Given this list of marker genes AP3B1, OPTN, CTDSPL, MYL9, PARD3 (par-3 family cell polarity regulator), CALM2, HIRA, MGAT5, TRIM22, NECTIN2, ZBTB20, RBMS1, PLOD2, KLK7, ARMCX2, SNX19, DST, PSMA3, ERBB4, CANX, BEX4, ADD3, ATP13A3, RBBP4, SPOCK1, SACM1L, GDE1, FAT1, UBE2L6, POSTN, KLK6, HNRNPC, DUSP14, RAI14, DPYSL3, ZNF185, MEGF9, SULF1, CXADR, GAB2, IARS1, SDC2, HOXA9, CORO2B, TOB1, PCK1, TUSC3 (tumor suppressor candidate 3), NBN, SMARCC1, RCAN1 (regulator of calcineurin 1), PTPN14, TOMM34, ACTR3, LANCL1, HTRA1, ST3GAL6, CHST2, KLHL9, LOX, RABGAP1L, PSMA6, MTX2, PSMA2, RAD23B, GRIK2, RAB1A, SKP1, GADD45A, HNRNPA3, SSBP2, PLXNB2, F3, CLIC5, MYLK, IGFBP7, ENSG00000260917, MTSS1, OSER1, CTNNBIP1 (catenin beta interacting protein 1), AKAP11, TSPAN3, TBC1D9B, PPP2CB, CFLAR, NFATC3, FGFR2, BIRC2, WT1-AS, EXPH5, ZNF516, KIF5B, CD200, PRDX6, AIF1, SULT1A2, BMP2, GMDS, CERS6, CAND2, YWHAE, PAPSS1, DLG5, IFIT1, PREPL, SERINC5, TRIM44, PTPN7, GPNMB, HMGN1, FERMT2, FOXC1, PTGDS, SGMS1, GHR, PARP1, SDC4, NEDD9, ADM, GLUL, CDC42EP3, ARHGEF18, TOMM20, CTBP1, FAM98A, DUSP1, ATXN10, BIRC3, TMED5, TBCA, PRKACB, SCHIP1, DAG1, CACNB2, CR1, RHOBTB2, RSBN1, CLIP3, EID1, MAGI2, ATP9A, GLOD4, ATP7A, ACBD3, CASP1, DDX17, DYRK1A, MCM6, MTDH, SEC61G, ACTG1, ATP6AP2, PRKCI, LUC7L3, PNMA2, LETMD1, MXRA8, USP9X, GJA1, DCAF8, CD47, NDN, ZC3HAV1, ITGB5, GTF2A2, ARID5B, CHI3L1, ISG15, CXCL2, TAX1BP1, HSP90AA1 (heat shock protein 90 alpha family class A member 1), GPRC5A, CAPN2 (NCBI Gene Id 824), XRCC5, PTH1R, G0S2, EIF4A2, RAB21, PMS2P3, TOM1L2 (NCBI Gene Id 246315), F8A1, HSPA2, FLRT2, COL3A1, SET, GAS1, BST2, EIF3M, NR3C1, CDS1, N4BP2L1, EFR3A, CDV3, YBX3, NPHS1, PDLIM5 (PDZ and LIM domain 5), ARL1, ULK2, SEMA3C, CAST, TRAM2, ITGA3, MECP2, TIAL1, GJA5 (gap junction protein alpha 5), SEMA5A, PODXL, C1R, ATP2A2, HNRNPA1, TLK1, KANK1 (NCBI Gene Id 23189), ITGB3, NPTN, VIM, FBXO21, B4GAT1, PLSCR1, AASDHPPT, COL4A6 (collagen type IV alpha 6 chain), BCAR3, CTNNA1, SEPTIN10, TMEM123, ING1, MYL12A, SP100, FGF1, RDX, UBE2D2, LITAF, SMARCA2, PAM (NCBI Gene Id 5066), PHLPP2 (NCBI Gene Id 23035), HNRNPDL, MCL1, MYO1B, TSPYL4, BMP7, COLQ, NAPG, CLEC16A, SUB1, TEAD4, TUBB2A, HSP90B1, CREB3L2, PPFIA4, ACSL3, IFT25, SPOCK2, TNNT2, HSPA5, PTPRO, PEX14, MORC3, RPN2, MTHFD2, ADORA1, GRK5, CYP1B1, PTPRD, STX7, DNAJA1, ATXN1, PLS3, ANXA1, WWP1, BCAM, CD164, PAFAH1B1, UGP2, NFE2L1, UNG, PRKAR2B, IQGAP2, GULP1, LPL, LSR, ECM2, SRGAP2, PTPN11, LEPROT, RHEBP1, XBP1 (X-box binding protein 1), NAMPT, UGCG, KCND3, CBLB, NUPR1, CRIM1, VCAN, PALLD, FRY, GNE, NEK7, PTGER4, AXL, NEBL, COL4A4, HMGN3, STAT1, IFI44, CITED2, FOSL2, UAP1, FLNA, GYG1, TRIM37 (tripartite motif containing 37), RARRES2, PCMT1, HSPA12A, TOP2B, PLCG2, MAFF, SERINC1, WARS1, TAPBP, MME, PLCE1, EPS15, PHYHIP, CALU, ARHGAP5 (NCBI Gene Id 394), NMI, VEGFA, CDC14A, IFITM1, HPGD, NTRK2, KBTBD11, RGS10, ELF2, TIMP1, SART3, MYO1E, SCRN1, AASS, CDKN1C, TCF21 (transcription factor 21), OAS2, AKAP10, DDN, KIAA0232, SEPTIN2, TGFBR3, TRIB2, CCDC6, N4BP1, IRS1, PDE4DIP, PFN2, FNBP1L, SLC2A3, FAM153A, FYN, TLE4, MYH9, OTUD4, IFI35, PAWR, ENPEP, GLUD2, C1S, CCN1, SYNPO, NDRG1, PRKAR1A, COL4A3, ANXA2P1, IGFBP2, ACADM, CMAHP, PAK1, XPO1, RNF11 (NCBI Gene Id 26994), MSH2, F2R (NCBI Gene Id 2149), APOL1, TMX4, CYP51A1, GSTA4, TRIM23, OSMR, ODC1 (NCBI Gene Id 4953), PLA2R1, PDE4B, CCN2, SEMA3B, TAP1, TYRO3, WT1, PDGFA, SEPTIN11, FNBP1, SERPINE1, VPS26A, APOD, SARAF, CAMSAP2, USP46, ITGAV, GMFB, CEBPD, DPP6, AGRN, PSMB9, AQP3, NAB1, THSD7A, DSTN, CD55, ARHGAP19, DCTD, GALC, CD2AP, NFASC, UBR2, ALDH3B1, MXRA7, FGF9, SLK, YWHAZ, MED21, PDIA3, DNM1L, OAS1, DNAJB9, LOXL1, CALD1, CHD3, TMEM259, TMED10, ABI1 (NCBI Gene Id 10006), VPS13D, HMCES, TSC22D3 (TSC22 domain family member 3), LRIG1, here is a description of the gene set: Genes down-regulated in glomeruli of kidneys from patients with diabetic nephropathy (type 2 diabetes mellitus). BACKGROUND: Diabetic nephropathy (DN) is a frequent complication in patients with diabetes mellitus. To find improved intervention strategies in this disease, it is necessary to investigate the molecular mechanisms involved. To obtain more insight into processes that lead to DN, messenger RNA expression profiles of diabetic glomeruli and glomeruli from healthy individuals were compared. METHODS: Two morphologically normal kidneys and 2 kidneys from patients with DN were used for the study. Glomerular RNA was hybridized in duplicate on Human Genome U95Av2 Arrays (Affymetrix, Santa Clara, CA). Several transcripts were tested further in independent patient groups and at the protein level by immunohistochemistry. RESULTS: Ninety-six genes were upregulated in diabetic glomeruli, whereas genes were downregulated. The list of overexpressed genes in DN includes aquaporin 1, calpain 3, hyaluronoglucosidase, and platelet/endothelial cell adhesion molecule. The list of downregulated genes includes bone morphogenetic protein 2, vascular endothelial growth factor (VEGF), fibroblast growth factor 1, insulin-like growth factor binding protein 2, and nephrin. A decrease in VEGF and nephrin could be validated at the protein level and also at the RNA level in renal biopsy specimens from 5 additional patients with diabetes. CONCLUSION: Results of oligonucleotide microarray analyses on control and diabetic glomeruli are presented and discussed in their relation to vascular damage, mesangial matrix expansion, proliferation, and proteinuria. Our findings suggest that progression of DN might result from diminished tissue repair capability. studied in species Homo sapiens from publication Baelde HJ, Eikmans M, Doran PP, Lappin DW, de Heer E, Bruijn JA (PMID 15042541) Human Gene Set: BAELDE_DIABETIC_NEPHROPATHY_DN